The following is a description of a gene set: The levels of second messengers such as Ca+2, cAMP and cGMP may regulate the response of the growth cone to a particular cue. Netrin-1 as a guidance molecule depends on intracellular Ca+2 concentration, coactivation of PI3K and PLCgamma, and the type of response depends on the levels of cAMP. Netrin first stimulates its receptor DCC, resulting in the activation of the enzyme phospholipase C. This then produces the messenger molecules, inositol-1,4,5-trisphosphate (IP3) and DAG, which in turn causes the release of Ca+2 from intracellular stores. Ca+2 release from the stores then activates TRPC channels on the cell surface. DAG activates TRPC3 and TRPC6 in a direct, membrane delimited manner, and IP3 may activate TRPC channels by depleting the ER Ca+2 levels. part of: Netrin-1 signaling studied in species Homo sapiens Reactome Pathway: Role of second messengers in netrin-1 signaling, and this is the list of marker genes: TRPC7, TRPC4, TRPC1, TRPC3, PITPNA, DCC (NCBI Gene Id 1630), PLCG1, TRPC6, NTN1, TRPC5